The following is a description of a gene set: Genes up-regulated in LNCaP cells (prostate cancer) by overexpression of SOX4 and down-regulated by its RNAi knockdown. from publication Liu P, Ramachandran S, Ali Seyed M, Scharer CD, Laycock N, Dalton WB, Williams H, Karanam S, Datta MW, Jaye DL, Moreno CS (PMID 16618720) Prostate cancer is the most commonly diagnosed noncutaneous neoplasm and second most common cause of cancer-related mortality in western men. To investigate the mechanisms of prostate cancer development and progression, we did expression profiling of human prostate cancer and benign tissues. We show that the SOX4 is overexpressed in prostate tumor samples compared with benign tissues by microarray analysis, real-time PCR, and immunohistochemistry. We also show that SOX4 expression is highly correlated with Gleason score at the mRNA and protein level using tissue microarrays. Genes affected by SOX4 expression were also identified, including BCL10, CSF1, and NcoA4/ARA70. TLE-1 and BBC3/PUMA were identified as direct targets of SOX4. Silencing of SOX4 by small interfering RNA transfection induced apoptosis of prostate cancer cells, suggesting that SOX4 could be a therapeutic target for prostate cancer. Stable transfection of SOX4 into nontransformed prostate cells enabled colony formation in soft agar, suggesting that, in the proper cellular context, SOX4 can be a transforming oncogene. Human Gene Set: LIU_SOX4_TARGETS_UP species: Homo sapiens, and this is the list of marker genes: DDX18 (DEAD-box helicase 18), FAM107B, TMED10, AGO1, KIFC3, PRSS23, THRB, BRAP, MBP, PPT2, SOX4, SUSD6, ADAM10, IL10RB, TMEM158, CES2, RBKS, DST, FEZ1, UBA3, ATRX, SUGP1, TBC1D13, PRDM2, PTP4A3, CD24, STN1, ZFAND6, ELAVL4, BMPR2, INTS9, ELK3, CREBRF, ATF6B, COX7C, GABARAPL1, RNF213, NSUN3, ILDR1, MPPE1, MAN2A1, POLDIP3, ISG20, USP31, SORL1, LINC00581, ATP2B4, FUT8, E2F3 (E2F transcription factor 3), PPP1CB, LGMN, EPDR1, EMC1, RRM2B, RGPD5, C1orf115, CTTNBP2NL, STAM, ATP7A, SLC33A1, PRDX6, ZNF281, KIAA0586, CSF1, BPGM, RANBP10, KLHL24, HBP1, TNFRSF21, ENPP4, PLK2, BTN3A3, LHFPL2, MORF4L1, USP43, CTAGE9, TMED1, NCOA4 (NCBI Gene Id 8031), YPEL5 (yippee like 5), TLE1, HBEGF, PDGFA, ARL4D, SPSB3, DUSP5, TMSB10, TUT4, GLP1R, TMEM143, ZNF318, ARHGAP19, PDS5A, PPP2R1B, LTN1, LIF, LITATS1, TMEM184B, SLC5A3, KBTBD4, RB1CC1, VPS8, HPN, PDE8A, FYCO1, PLPP3, TBL1X, TSC22D2, FCN3, LASP1, DENND5A, TUBA1A, THBS1, RP2, LEF1, IL6R, EGFR, VRK2, SOX9, ENPP5, DMAC2L, DICER1, WBP1L, SWAP70, FGF6, MLYCD, HSDL2, WWTR1, COMMD2 (NCBI Gene Id 51122), RYK, PDE6D, TNFSF10, TBXT, TSPAN31, CUX1 (cut like homeobox 1), ATR, ERLIN2, CLUAP1, BCL10, KLRC1, PXDN